Given this list of marker genes SPG7, FXN, NEFL, GFAP, PI4KA, here is a description of the gene set: species: Homo sapiens Human Gene Set: HP_CERVICAL_SPINAL_CORD_ATROPHY Cervical spinal cord atrophy Atrophy of the cervical segment of the spinal cord.